The following is a description of a gene set: species: Homo sapiens Genes up-regulated in polymorphonuclear leukocytes (9h) infection by A. phagocytophilum: heat killed versus live bacteria. Human Gene Set: GSE2405_HEAT_KILLED_VS_LIVE_A_PHAGOCYTOPHILUM_STIM_NEUTROPHIL_9H_UP Polymorphonuclear leukocytes (PMNs) were obtained from healthy individuals in accordance with protocols approved by the Institutional Review Board for Human Subjects at the University of Minnesota and the National Institute of Allergy and Infectious Diseases. PMNs (107) were combined on ice with live S. aureus (108) or with live or heat-killed A. phagocytophilum (bacteria isolated from 5x106 infected HL60 cells for a ratio of 1 infected HL60 cell: 2 PMNs, ~ 5-20 A. phagocytophilum: PMN) in wells of a 12-well tissue culture plate (pre-coated with 20% autologous normal human serum). Unstimulated control assays received either buffer (for S. aureus comparisons) or clarified HL60 lysate (for A. phagocytophilum comparisons). Plates were centrifuged at 350 x g for 8 min at 4oC to synchronize phagocytosis and incubated at 37 deg. C in a CO2 incubator for the indicated times. At the indicated times, tissue culture medium was aspirated from the plate and PMNs were lysed directly with RLT buffer (Qiagen, Valencia, CA). Purification of PMN RNA and subsequent preparation of labeled cRNA target was performed as described in Methods. Labeling of samples, hybridization of cRNA with HU133A oligonucleotide arrays (Affymetrix, Santa Clara, CA), and scanning were performed according to standard Affymetrix protocols ( http://www.affymetrix.com/pdf/expression_manual.pdf ). Experiments were performed in triplicate, using PMNs from three healthy individuals for each treatment. from publication Borjesson DL, Kobayashi SD, Whitney AR, Voyich JM, Argue CM, Deleo FR (PMID 15879137), and this is the list of marker genes: LASP1, YIPF4, BST2, CD1D (CD1d molecule), RNGTT, ING3, ATP5MG, SNHG6, CYRIA, RGS2, TRAPPC12, INPP5B, COX6C, TRMT112, PDCD6, SDHD, TSPAN31, SSR4, SEM1, PDHB, NMT1, MAK16, POLI, ASB11, INTS8, EIF3K, RBBP7, TBCA, TTC39B, FAM120B, PSMA2, SART3, TSPYL1, RPP14, RPL37, FCRL1, ADI1, GHITM, APEH, EXOSC5, FERMT3, ARPC5L, STK26, DNAJB11 (DnaJ heat shock protein family (Hsp40) member B11), HNRNPAB, ARL6IP1, HSPBP1, KPTN, ASNSD1, FYB1, RBM48, FABP1, TNFAIP8L2, COX6A1, DNAJB6, PGAM1, ZDHHC13, UBE2E1, MCOLN3, GRK6, MRPL33, GPR83, POLR1D, UBXN6, MAGOH, FAM162A, CACUL1, MPST, TRAPPC14, PXYLP1, CDC37, RNF166, PRPF40A, SS18 (NCBI Gene Id 6760), S100A10, FAM98C (NCBI Gene Id 147965), PPP1R11, TUT1, AKR1A1, YWHAH, TUBA1A, RRH, GTF2H2, PPP4R3A, AK2, CWC15, SENP2, GIGYF2, CREBZF, TRAPPC2L, HERPUD1, ARF6, IFI27, ITGB1BP1, ERLEC1, GRB2, CMC1, SIKE1, AKNA, GNPAT, GNGT2, PSMC3, LETM1, DUSP6, ADPRHL1, ATP6V0C, PIN1, PSPH, SF3B3, SIGMAR1, IFRD2, RASGRP2, WNT10A, CANT1, KLHDC1, HNRNPC, LSM7, EIF3D, FIBP, ATP6V0D1, APOC3 (NCBI Gene Id 440838), NOL6, UBE2L3, FBXL6, OXCT1, SMCHD1, MYL6, HNRNPH1, HGS, PSMD4, ABRACL, SNRPG, PCDHA12, DDX24, UNC119, LNX2, MDH2, USE1, ETF1, NCOA7, PRDX2, NPM1, MTMR1, MIDN, SGK3, MANF, CKB, HPRT1, BOLA3, PPCDC, NUDT3, IRF2BP2, CRABP2, VMP1, C11orf58, HDDC2, NDUFA4, SAR1B, LDHA, ANO10, COL9A3, SP4, CNR2, SNRNP27, RSPRY1, SSBP1, NUBP1, HAUS2, ARL5A, LTA4H, STPG3, COX5A, PRPF19, ZNF205, EML2, ELOC, POLR1F, C18orf32, COPS2, BTF3, RAMAC, SGMS1, TBC1D10A, ADH5, NDUFB11, C5orf34, CRIP1, HNRNPA3, BCL2L11, CHMP4B, GSAP, HCLS1, ZNF467, PPM1J, PAPOLA (poly(A) polymerase alpha), HHAT, PSENEN, ENG, CTSD